Given this list of marker genes Wdr11, 5730455P16Rik, Fam91a1, Trip11, Tbc1d23, here is a description of the gene set: Mouse Gene Set: GOBP_VESICLE_TETHERING_TO_GOLGI The initial, indirect interaction between a transport vesicle membrane and the membrane of the Golgi. This interaction is mediated by tethering factors (or complexes), which interact with both membranes. Interaction can occur via direct binding to membrane phospholipids or membrane proteins, or via binding to vesicle coat proteins. This process is distinct from and prior fusion. species: Mus musculus